Given this list of marker genes Prkcb, Nacc1, Slc4a10, Pak5 (NCBI Gene Id 73084), Fstl3, Cacna2d2, Cdan1, Rbms3, Tbr1, Syngr2, Zbtb39, Tm9sf3, Pik3ca, Hnrnph3, Mtbp, Clec12a, Col1a1, Cdyl2, Epas1, Prlr, Mtf1, Prc1, Ufl1, Sec61a2, Cyp4a12a, Sectm1a, Abcd2, Garem1, Lima1 (LIM domain and actin binding 1), Cnih3, A830018L16Rik, Pcnx1, Hccs, St8sia3, Nectin2, Napg, Stk11ip, Ccdc184, Ms4a7, Ube3a, Zfp277, Ank3, M6pr, Yy1, Cntnap2, Gnpnat1, Dcaf17, Thbs1, Nrl, Arhgap21, Man1a2, Clock (NCBI Gene Id 620729), Zfp85 (zinc finger protein 85), Zfhx4, Angptl1, Rxfp2, G3bp2, Sumo3, Eif4e2, Alox12e, Psd3, Hnrnpd, Stimate, Kpna1, Ndc80, Elavl3, Pkp2, Nrk, Rnd3, Cfap90, Rtp3, Arhgef12, Epsti1, Slc1a2, Pde1c, Sp1, Fcrla, Zfp493, Nhlh1, Arhgap44, Slc25a23, Eeig1, Nexn, Znrf2, Flrt2, Plch1, Nsg2, Yes1, Ccr1, Manf, Luc7l3, Rxrg, Rai14, Dgkk, Tram1, Capn5, Zfp273, Fgfr2, Pla2g2f, Septin3, Slc4a8, Clip3, Ppp1r3b, Sgip1, Cbx6, Triml1, Jazf1, here is a description of the gene set: from publication Chen Y, Wang X (PMID 31504780) Mouse Gene Set: MIR_450A_2_3P studied in species Mus musculus Genes predicted to be targets of miRBase v22 microRNA mmu_miR_450a_2_3p in miRDB v6.0 with MirTarget v4 prediction scores > 80 (high confidence targets).